Given this list of marker genes CFDP1, RIDA, RBP7, AP1S2, ITFG1 (NCBI Gene Id 81533), UFL1, HSPH1, TMEM208, EMC8, C16orf87, MKRN2, FAM216A, CNN3-DT, EIF4EBP1 (NCBI Gene Id 1978), POLR3K, RNF139, XPC, LCMT1, TERF2IP, NAE1, CBFB, UTP4, ORC6, IER5, EFEMP1, MDC1, DDHD2, IKBKB, AFF3, DNAJB1, CENPN, HOXA9, TYW3, UBE2V2, STOML1, SELENOP, APRT, RSL1D1, MAP1LC3B, TSC22D3, C2CD2, FAM201A, CBS, RAB11FIP3, CDC40, JAGN1, PCOLCE2, PRMT7, ZNF83, MRPS34, FAM107B, DTNBP1, KATNB1, IGFBP7, ARMCX1, BOLA1, PAM, EIF3E, VKORC1, NRCAM, DYNC1LI2, CBY1, HSDL1, LXN, HSD17B8, TMCO6, SLC2A13, UQCRB, SLC39A4 (solute carrier family 39 member 4), CNOT1, DCAF10, ZNF165, TMEM18, ATMIN, FABP5, RBL2, JPT2, GPRC5B, MON1B, SSR1, KCNJ2, UNG, ZDHHC7 (NCBI Gene Id 55625), MPPE1, SYBU (syntabulin), SQLE, IQCH-AS1, MARVELD3, KRCC1, MRPL13, AADAT, SRD5A3, MRPS25, DSCC1, CXCL12, ZNF813, CYRIB, EPHA7, LONRF1, CTCF, LMBRD1, MPHOSPH6, SULT1A2, CCP110 (centriolar coiled-coil protein 110), MSC-AS1, MAN1A2, TRMU, IDH2, ERO1B, ABCC6, PLPP5, NSMCE2, KRTDAP, MBOAT2, RARB, CACYBP, BICRAL, SPG7 (SPG7 matrix AAA peptidase subunit, paraplegin), ZNF91, FUT10, RGCC, GINS2, OAT, SULT1A1, CDH1, SIAH1, ETFB, ZNF239, TCF25, RFT1, C16orf46, ECHDC2, MRTFB, ESRP1, CHKB-DT (NCBI Gene Id 101928825), CDR2, KANK1, TCF24, CD109, CDS1, PRPF3, ERCC4, ZNF879, H2AJ (H2A.J histone), COQ9, ADAM9, N4BP2, GK, SLIT2, PHLPP2, COX4I1 (cytochrome c oxidase subunit 4I1), BACE1, ASH2L, USP7, ZNF276, TENT4B, MRPL28, KHDRBS3, ARMC1 (armadillo repeat containing 1), NDUFB10, CCNE1, PCDH19, TSPO, ARHGEF26, PHF20L1, MACROH2A2, MCM3, PROSER3, GPANK1, DDX19A, LRRC41, KBTBD11, ERLIN2, ZNF700, HOXA5, SNRNP25, CHD9, EIF3H, HOXC4, QPRT, NDUFB9, AGPAT5, AGO2 (NCBI Gene Id 286109), SFXN4, DDX28, ANKRD46, ANKRD11, CDT1, AARS1, PNMA8A, NAP1L3, TNFRSF11A, CTH, DEF8, TERF1, CMC2, HDDC2, here is a description of the gene set: Genes down-regulated in macrophages: control versus glioblastoma conditioned. species: Homo sapiens Human Gene Set: GSE18804_SPLEEN_MACROPHAGE_VS_BRAIN_TUMORAL_MACROPHAGE_DN Active immunotherapy is a promising strategy for anti-angiogenic cancer therapy. Recently, we have reported that a vaccine using human umbilical vein endothelial cells (HUVECs) induced specific anti-endothelial immune responses in the most of immunized patients, and resulted in tumor regression in some patients with recurrent malignant brain tumors, whereas not in colorectal cancer patients. In this study, we hypothesized that non-hypoxic perivascular tumor associated macrophages (TAMs) in colorectal cancer, but not in glioblastoma, might negatively alter the therapeutic efficacy of anti-angiogenic active immunotherapy. To test this hypothesis, we examined global gene expression profiles of non-hypoxic macrophages stimulated in vitro by soluble factors released from tumor cells of human glioblastoma U-87MG (‘brain TAMs’) or colorectal adenocarcinoma HT-29 (‘colon TAMs’).